The following is a description of a gene set: Human Gene Set: CHARAFE_BREAST_CANCER_BASAL_VS_MESENCHYMAL_DN Genes down-regulated in basal-like breast cancer cell lines as compared to the mesenchymal-like ones. A better molecular characterization of breast cell lines (BCL) may help discover new markers to apply to tumour samples. We performed gene and protein expression profiling of 31 BCL using whole-genome DNA microarrays and immunohistochemistry (IHC) on 'cell microarrays' (CMA), respectively. Global hierarchical clustering discriminated two groups of BCL: group I corresponded to luminal cell lines, group II to basal and mesenchymal cell lines. Correlations with centroids calculated from a published 'intrinsic 500-gene set' assigned 15 cell lines as luminal, eight as basal and four as mesenchymal. A set of genes was differentially expressed between basal and luminal samples. Mesenchymal and basal subtypes were rather similar and discriminated by only genes. The expression of 10 proteins (CAV1, CD44, EGFR, MET, ETS1, GATA3, luminal cytokeratin CK19, basal cytokeratin CK5/6, CD10, and ERM protein moesin) encoded by luminal vs basal discriminator genes confirmed the subtype classification and the validity of the identified markers. Our BCL basal/luminal signature correctly re-classified the published series of tumour samples that originally served to identify the molecular subtypes, suggesting that the identified markers should be useful for tumour classification and might represent promising targets for disease management. from publication Charafe-Jauffret E, Ginestier C, Monville F, Finetti P, Adélaïde J, Cervera N, Fekairi S, Xerri L, Jacquemier J, Birnbaum D, Bertucci F (PMID 16288205) studied in species Homo sapiens, and this is the list of marker genes: TRAF3, RBM24, ZEB1, LOXL2, FAM171A1, MB21D2, MAP1B, SHOX2, SH2B3, MMP16, KLF2 (KLF transcription factor 2), CNKSR3, DPY19L1, ARHGAP17 (NCBI Gene Id 55114), TRIO, GFPT2, PFKP, GNG11, AK5, GRB10, ARNT2, GRK5, CMTM3, IL11, NUAK1 (NCBI Gene Id 9891), BCAT1, FZD2, ZCCHC24, ALPK2 (NCBI Gene Id 115701), RGS7, GULP1, ARHGEF40, PDCL3, EDIL3, TUBB2A, SEMA3A, UTRN, PNMA2, BDNF, CD99, RNF182, SCG2 (secretogranin II), CIBAR1, CCDC74A, FLNC, STRADB, TTC28, APLP1, COL6A2, ADAMTS12 (NCBI Gene Id 81792), KIF3C (NCBI Gene Id 3797), TNIP1